Given this list of marker genes DPYD, CRMP1, XDH, DPYS, ALDH6A1, DPYSL5, GDA, DPYSL4, DPYSL3, DPYSL2, here is a description of the gene set: Human Gene Set: GOBP_NUCLEOBASE_CATABOLIC_PROCESS species: Homo sapiens The chemical reactions and pathways resulting in the breakdown of a nucleobase, a nitrogenous base that is a constituent of a nucleic acid.